Given this list of marker genes NOD2, DNASE1L3, CASP10, MST1, GJA1, CAPN5, IL2RA, IL10, FASLG, XIAP, CD27, IL2RB, ERCC6, CD247, MIF, CHD6, NLRP1, STAT4, FOXP1, ERCC1, CCR1, IKBKG, HLA-B, IL6, IRF4, IL36RN, TNFRSF1A, AIRE, HLA-DRB1, ANKRD55, C4A, TNFAIP3 (TNF alpha induced protein 3), BMP4, IL12A, BIRC3, IL23R, TLR4, TCF4, GPR35, TKT, SEMA4D, LACC1, MBTPS2, PTPN2, KLRC4, MALT1, BTNL2, PTPN22, ERCC4, AP1S3, ATOH7, LRBA, STUB1, MEFV, UBAC2, ERCC8, BCL10, NLRP3, ERAP1, IL12A-AS1, IFNGR1 (interferon gamma receptor 1), BLM, FAS, here is a description of the gene set: Human Gene Set: HP_UVEITIS Inflammation of one or all portions of the uveal tract. studied in species Homo sapiens Uveitis